Given this list of marker genes Slc4a11, Mylk (NCBI Gene Id 68242), Serpinb6a, Tspo, Cln3, Bad, Trpv3, Mir99a, Atp1a1, Ang, Clcn2, Wnk1, Scn7a, Mir29c, Xrcc6, Wnk3, Mir9-2, Epo, Pck1, Relb, Zfp36l1, Dysf, Akr1b1, Lrrc8d, Casp3, Capn3, Mir100, Vps13a, Serpinb6e (NCBI Gene Id 435350), D1Pas1, Mir9-1, Trpv4, Ninj1, Casp1, Efhd1, Nlrp3, Mlst8, Slc2a1, Slc12a6 (NCBI Gene Id 93718), Pkd2, Mir9-3, Serpinb6d, Ddx3x, Serpinb6b, Letm1, Fbp1, Bdkrb2, Serpinb6c, Mir137, Scn2a, Aqp1, Mir7b (NCBI Gene Id 723883), Mir29b-1, Tifab, Slc25a23, Xrcc5, Mtor, Usp15, Ybx3, Micu1, Mir204, Nlk, Mir29b-2 (microRNA 29b-2), Ptgs2, Pycard, Oxsr1 (oxidative-stress responsive 1), Mir451a, Lrrc8c, Mir434, Abcb1a, Prkg2, Slc2a4, Map2k7, Lrrc8e, Mir30b, Rcsd1, Rptor, Aqp5, Stk39 (serine/threonine kinase 39), here is a description of the gene set: Mouse Gene Set: GOBP_CELLULAR_RESPONSE_TO_OSMOTIC_STRESS species: Mus musculus Any process that results in a change in state or activity of a cell (in terms of movement, secretion, enzyme production, gene expression, etc.) as a result of a stimulus indicating an increase or decrease in the concentration of solutes outside the organism or cell.